The following is a description of a gene set: Progressive hearing impairment A progressive form of hearing impairment. studied in species Homo sapiens Human Gene Set: HP_PROGRESSIVE_HEARING_IMPAIRMENT, and this is the list of marker genes: ACTG1, NOTCH2NLC, TPRN (taperin), MT-ND1, GATA3, FGF3, P2RX2 (purinergic receptor P2X 2), LARS2, ALMS1 (ALMS1 centrosome and basal body associated protein), GOSR2, GRXCR1, MT-ND6, SERPINB6, WFS1, MT-CO2, POLR3GL, GIPC1, NLRP3, TWNK, MCM2, MT-TS2, SYNE4, MIR96, ATP1A3 (ATPase Na+/K+ transporting subunit alpha 3), LRP12, MT-CYB, MT-TC, MT-CO1, SLC30A9, MT-TQ, POU3F4, ARSG, MYO6, MYO3A (myosin IIIA), TBC1D24, MT-CO3, MT-TL1, DMXL2, MT-ND5, TIMM8A, MYH14, KMT2D, GJB2, SCD5, NDUFA1, GFER, MPZL2, MT-TF, GJB6, OPA1, IARS2, MT-TV, GSDME, MT-TK, RILPL1, MT-TW (NCBI Gene Id 4578), MPZ, DIAPH1, PEX11B